The following is a description of a gene set: Genes having at least one occurrence of the motif TTCCCGKAA in the regions spanning 4 kb centered on their transcription starting sites. This matches the transcription factor binding site V$STAT_01 (v7.4 TRANSFAC). Human Gene Set: STAT_01 species: Homo sapiens, and this is the list of marker genes: S100A3, RFX4, ADAMTS9, PRPH, PANX1, FBXL9P, IGFALS, RAB10, VIP, LEP, DCUN1D3, RELCH, PCDH1, MYOG, LMO3, ARHGAP36, TMEM100, IRF8, ZNF546, BDNF, SERPING1, CLU, ACBD5, DTX2, SERTAD3, IFT43, HNRNPR, NME7, GPC4 (NCBI Gene Id 2239), ETV5, RPS15A, ASCL3, JADE2, POLR2M, ZNF233, AGT, LIX1, IFT80, TNIP2, NOA1, NFIL3, SARM1, GPR153, SEC24C (NCBI Gene Id 9632), SYMPK, THPO, VTN, TMEM60, PPP1R9B, BCL6, STXBP6, SNCB, EHMT2, GPATCH4, ADORA1, KLF13, LPO, SOD1, HACE1, ICAM1, BMPR2, PPARGC1B, SCRG1, MAP2K6 (mitogen-activated protein kinase kinase 6), ZNF112, USP25, PVALB, GPHB5, LTA, APBA1, SCN2A, ZNF423, PLSCR1, SDC1, TMOD3, BACH2, PCOLCE, MAP2K3, ZNF516-DT, MYO18A, PSMD3, ABCC5, NTF4, PDLIM1, CXCL11, FLT1, RAB11B, ATXN7L2, ADAMTSL3, NR4A3, TRIM25, TMEM95, LAPTM4B, SCAMP3, PLA2G3, CREM, SBF2, RASA1, SMC4, EDEM2, LINC00652, AP2M1, RUNX3, XRCC1, HOXB4, SLC1A5, HHATL, LYRM1, DGKZ, NDUFS2, TNFSF11, MASP2, FGA, DOCK4, CD40LG, CXCL17, MECP2, BCLAF1, SOCS2, LIN54 (lin-54 DREAM MuvB core complex component), DUSP4, SET, VASN, UBR1, TCERG1, PHC1, IL6ST, GABBR1, PLEC, C4BPA, ZNF180 (zinc finger protein 180), NUDCD1, GZMB, ASXL1, SHKBP1, BTBD1, NHSL2, BRINP3, COQ8B, PI4K2A, PALS2, TFAP2C, RBM14, CCDC25, AGRP, PRDM1, CDK18, AKT1, CERT1, HOXA2 (homeobox A2), CNOT4, PSD (pleckstrin and Sec7 domain containing), SLC6A14, HJV, MAB21L1, SMC6, SLC26A9, RRAS, ZNF689, CLEC1B, TAL1, CHI3L1, NEK6, EXPH5, ARF3, POLR2B, CACNA1D, IL18RAP, PROK1, TSHZ2, JUN, WDR81, DLX4, MAP4K4, VGF, NT5C2, CPNE1, TNS2 (NCBI Gene Id 23371), PPARD, C1QTNF7, MIR22HG, NEDD4 (NCBI Gene Id 4734), EIF4E, CREBRF, CKB, TCEA2, CCL2 (NCBI Gene Id 6347), TET2, ATP5MC2, FAM98B, GRB10, COLQ, LASP1, CBLIF, GMPPB, IPO11, SLC38A5, IL18BP, MED24, ZFP36L1, ANK3, GEN1, PNMA1, CEP41, MBD6, BCL9, SDHAF2, OIT3, F9, MRPL24, GSK3A, FN1, SEPTIN9, OSM, HOMER2, ARIH1, ADAMTS4, IRF2BP1, BET1, TRIM15, ARL6IP5, LIN28A, FANCB, CBL, SSBP4, ENPP2, CCND2, IWS1, POLK, RFFL, PTCHD4, IRF1, ZNF582, BATF, HOXD9, FOXA3, CITED4, TMEM208, PPP2R3A, NKG7, ITPKC, NRP1, RDH10, MOSPD2, IFTAP, PAN2, ASPH, SKIDA1, CISH, GK, VAX1, CPSF7, EMCN, ZNF235, SRSF6, RAB3B, HSD3B7, MAFF, DRC7